The following is a description of a gene set: Human Gene Set: GOBP_2FE_2S_CLUSTER_ASSEMBLY The incorporation of two iron atoms and two sulfur atoms into an iron-sulfur cluster. species: Homo sapiens, and this is the list of marker genes: HSCB, ISCU, BOLA2B, GLRX5, FXN, BOLA2, FDX2, NDUFAB1, LYRM4, GLRX3 (glutaredoxin 3), NFS1